Given this list of marker genes MOCS3, KATNB1, SYCE2, PRM3, LTA, ALDOA, VPS29 (VPS29 retromer complex component), HEXIM2, UNC93B1, HIPK2, UBL7 (ubiquitin like 7), CSNK2B, NXN, ARHGAP26, PRSS42P, TAF8, PPM1E, NKD1, CTDNEP1, CUL9, CDCA4, UST, RCN1, RNF169, NDUFC2, KAZN, MEN1, SH3BP2, ACAT2, PARP3, MYO1C, CHST1, HLA-DMB, IFI35, RNF114, ATPSCKMT (ATP synthase c subunit lysine N-methyltransferase), PPP3CC, NF2, TTLL6, AK2, KLHL30, BCS1L, PLA2G10, OS9, DHX58, AP1S1, ZNF784 (NCBI Gene Id 147808), SLIRP, HPCA, PLEKHF1, ZNF18, SMG9, SPAG5, OST4, NUDT5, CTU2, IL18BP, TSPAN31, UBE2L3, PSMA6, UHRF1, CYP19A1, ADAMTS3, GDPD5, MAP3K8, GLIPR2, CERS3, NUP62, FREY1, GPI, MFAP3, RAB27B, ST6GALNAC5, SDF4, SLC26A7, GAS7 (NCBI Gene Id 8522), ARHGDIA, SCYL3, POMGNT2, AARS2, KAT2A, POLR2A, PSMB5, TAP1, ZNF804A, ZP1, USP18, PSMD14, SERF2, TIAM1, COG4, NEU2, ACTR1A, LMAN2, LRRC3, PARP9, PDLIM4, MRPL19, THOC7, CYTH1, MTUS2, SARS1, CLRN3, SLIT2, THRB, ZDHHC8, HDAC1, PAFAH2, FOXB1, MOV10, BCAP31, CD109, FNTB (NCBI Gene Id 2342), DLL3, LRP8, UBA7, IGHMBP2, VSIG1, IFIT1B, SEMA4D, SCN2B, CASP4, AFG2B, ASXL2, HMG20B, SRGAP3, SH3GL1, RAB1B, STX1A, G0S2, RAMP2, ADSL, MTMR11, ESS2, METTL22, NAV1, HSPB8, SULF2, NDUFA13, TMEM259, PRND, TRH, IFI27L2, COX6B2, SH3BP1, TBCD (NCBI Gene Id 6904), PPM1B, SDHB, ACAT1, PINX1, ZNF23, SLFN12, DENND5A, PILRA, DDC, SRA1, TOM1 (NCBI Gene Id 10043), FXR2 (FMR1 autosomal homolog 2), MAP1S, GALR3, CFAP91, GBP2, MRPL12, M1AP, P2RX5, CACNB1, LCN12, ASCL2, MRPS25, SMIM5, TRAPPC5, MRPL42, ATPAF2 (ATP synthase mitochondrial F1 complex assembly factor 2), FDPS, TNNI1, CABYR, CNOT3, HLA-E, ZBTB7B, ZBP1, TEX38, PHC2, ARAP2, C1S, C19orf33, SLC22A9, POU4F2, CASP14, TFAP2B (NCBI Gene Id 7021), SRP68, POLE2, TMEM256 (transmembrane protein 256), ORC2, C2, DCAF4, NPC2, PLEKHH3, SFT2D2, DHX30, CNPY2, here is a description of the gene set: from publication Ventre E, Brinza L, Schicklin S, Mafille J, Coupet CA, Marçais A, Djebali S, Jubin V, Walzer T, Marvel J (PMID 22942430) Human Gene Set: GSE32423_CTRL_VS_IL7_IL4_MEMORY_CD8_TCELL_DN Genes down-regulated in comparison of memory CD8 T cells versus those treated with IL4 and IL7. studied in species Homo sapiens Effects of IL-4 on CD8 T cells functions are largely unknown. IL-4 induces survival and proliferation of CD8 T cells, but several studies suggest that IL-4 could also affect several functions of CD8 T cells such as cytotoxicity. Our team has shown that IL-4 repress the expression of Ccl5 in vitro. To define more precisely the impact of IL-4 on CD8 T cells, we performed a whole genome expression microarray analysis of naive and memory CD8 T cells cultured in presence or absence of IL-4. This approach allowed us to define the IL4-gene-expression signature on CD8 T cells.